Given this list of marker genes KIF21A, PALM3, PDZD2, MMP3, CYB5R1, AKAP9, SRR, HSPA4, ITGAX, MYADM, UCHL1, KRT6B, SDC4, GAD1, MGP, CCNJL, AHSA1, TFRC, ZNF672, PLCD4, UBQLN1, BRD2, CCN1, HSPA8, CCNL2, PSMC4, PRKACB, CCL13, TSC2, PSMA7, GDF15, NID1, TM4SF1, MYO1E, RRP12, STXBP3, FOXJ3, ABHD4, here is a description of the gene set: studied in species Homo sapiens Human Gene Set: APPIERTO_RESPONSE_TO_FENRETINIDE_UP Fenretinide (4-HPR) is a synthetic retinoid with antitumor activity, which induces apoptosis in cancer cell lines of different histotypes. To identify genes contributing to its apoptotic activity in ovarian cancer cells, we monitored, by cDNA arrays, gene expression changes after 4-HPR exposure in A2780, a human ovarian carcinoma cell line sensitive to the retinoid. Among the differentially expressed transcripts, PLAcental Bone morphogenetic protein (PLAB), a proapoptotic gene, was the most highly induced. In a panel of ovarian carcinoma cell lines with different 4-HPR sensitivities, PLAB upregulation was associated with cellular response to 4-HPR, its overexpression increased basal apoptosis and its silencing by small interfering RNA decreased the ability of 4-HPR to induce apoptosis. PLAB induction by 4-HPR was p53- and EGR-1 independent and was regulated, at least in part, by increased stability of PLAB mRNA. PLAB up-modulation by 4-HPR also occurred in vivo: in ascitic cells collected from patients with ovarian cancer before and after 4-HPR treatment, PLAB was upmodulated in 2/4 patients. Our results in certain ovarian cancer cell lines indicate a role for PLAB as a mediator of 4-HPR-induced apoptosis. The correlation of increased PLAB in vivo with antitumor activity remains to be established. from publication Appierto V, Villani MG, Cavadini E, Gariboldi M, De Cecco L, Pierotti MA, Lambert JR, Reid J, Tiberio P, Colombo N, Formelli F (PMID 17213814) Genes up-regulated in A2780 cells (ovarian carcinoma) exposed to fenretinide.